Given this list of marker genes Rnf213, H2-T23, Serpina3g, Ifit1bl1, Igtp, Bst2, Ifi47 (interferon gamma inducible protein 47), Tap1, H2-T22, Slirp, Tapbp, Zbp1, Gbp7, Ifi27l2a, Lgals3bp, B2m, Plac8, Iigp1, Ly6a, Psme2, Xaf1, Samhd1, Psmb10, Stat1, Klrc1, H2-Q7, Gbp4, Parp14, Gbp2, Plaat3, Tap2, Apobec3, Rtp4, Psmb9, Tmbim6, Parp9, Gbp9 (NCBI Gene Id 236573), Ifit3, Psmb8, Psme1, Rbm3, Sp110, here is a description of the gene set: Cytokines mediate cell-cell communication in the immune system and represent important therapeutic targets. A myriad of studies have highlighted their central role in immune function, yet we lack a global view of the cellular responses of each immune cell type to each cytokine. To address this gap, the authors created the Immune Dictionary, a compendium of single-cell transcriptomic profiles of more than 17 immune cell types in response to each of 86 cytokines (>1,400 cytokine-cell type combinations) in mouse lymph nodes in vivo. A cytokine-centric view of the dictionary revealed that most cytokines induce highly cell-type-specific responses. For example, the inflammatory cytokine interleukin-1β induces distinct gene programmes in almost every cell type. A cell-type-centric view of the dictionary identified more than 66 cytokine-driven cellular polarization states across immune cell types, including previously uncharacterized states such as an interleukin-18-induced polyfunctional natural killer cell state. species: Mus musculus Mouse Gene Set: CUI_T_CELL_GD_IL27_RESPONSE_UP Genes positively differentially expressed in cell type: γδ T cell upon treatment with cytokine: IL-27 in mouse lymph nodes in vivo. from publication Cui A, Huang T, Li S, Ma A, Pérez JL, Sander C, Keskin DB, Wu CJ, Fraenkel E, Hacohen N (PMID 38057668)